Given this list of marker genes FNDC3B, TSPYL5, PLLP, RAB33A, BEX1, LACC1, SLC11A2, CFH, CD200, DNAJB2, HIVEP2, ITM2A, IFIT3, ZNF91, GLMP, LINC01943, PAQR3, DUSP5, ITPR1, ZSCAN30, ASAH1, BEX2, VCAM1, FOXN3, RNF213, H2BC5, CXCL16, MTRES1, MOBP, ZNF678, HEXA, NR1D2, STC2, LRRC1, TFEC, KCTD7, ATP2C1, MYLIP, ACSL5, HMOX1, CEBPD, SIPA1L2 (signal induced proliferation associated 1 like 2), APOLD1, PLPP3, OSMR, PARP6, HES4, ENTPD1, PIK3C2B, DNASE2, CPQ, KALRN, INPP1, ACP5, SNHG7, RSAD2, CEBPB, TNFAIP3, H2AJ, C11orf96, FRMD3, KHNYN, COL4A1 (collagen type IV alpha 1 chain), DIRAS3, RECK, PCTP, TFPI, RGS2, SMOX, ETFRF1, PARD3B, VPS41, RANBP3, SDC4, LRIF1, FAM167B, PTPRM, OPN3, IFIH1, JAG1, H2AC6, COLEC12, H1-0, CXCL3, SEL1L, LETMD1 (NCBI Gene Id 25875), ERAP1, KDM2A, CDH11, HNMT, TPP1, ST3GAL5, PTGFRN (NCBI Gene Id 5738), IL1R1, ITGA1, GABBR1, SPATA18, ANKRD6, IL7R, ATF3, USP47, SMARCE1, CD109, H2AC18, KLF4, ACVR2B, CEACAM1 (NCBI Gene Id 634), MYL9, FBN1, QPCT, CREG1, DKK3, GCNT2, CD58, PCMTD1, ART4, RAPGEF5, GALNT11, ZFP36L1, PLAAT4, BIVM, C2CD2, RORA, LRRC8B, LIMCH1, SSH1, HEY1, ZNF71, CYB5R1, NUDT16, TMEM45A (transmembrane protein 45A), CXCL6, SH3KBP1, MARCHF3, ITFG1, CEP290, ZNF267, CRACD, IFI44, GVINP1 (GTPase, very large interferon inducible pseudogene 1), ENTPD4, CRISPLD1, CNPPD1, CASP1, PDZD2, IFIT2, FLT1, VLDLR, ACTA2, NFIL3, IGF2R, ATL1, SAR1A, SPAG16, RIT1, ZNF503, TLR3, CHD2, ZNF667-AS1, ADAMTS18, PLEK2, ABHD5, TXNIP, GFPT1, MESD, RFTN1, EPSTI1 (epithelial stromal interaction 1), LYRM7, KCNJ2, SLC40A1, ZNF655, PPM1D, CFB, TCN2, ANKRD12 (ankyrin repeat domain 12), CAST, STX12, PCDH17, ICAM1, BRWD1, PAPPA, TCTA, LRRC32, CTNS, COL5A1, TSPAN31, TSC22D1, GLCCI1, SOD2, CHST2 (carbohydrate sulfotransferase 2), CHN2, SNX29, KLHL6, PITPNM3, GDF3, OLAH, GPRASP3 (NCBI Gene Id 80823), APH1B, SLC25A51, CPPED1, EDNRB, CCL2, SLC2A3, LPP, PTPN4, DUSP4, PRCP, KIF16B, SCAMP1-AS1, APOL1, LGALSL, FBXO22, TNFRSF11A, SMCR8, PRNP, ALDH6A1, NNT-AS1, RNF13, ARID5B, GLIDR, PPP1R3C, EMC6, MID2, ZSCAN29, SESN3, C6orf58 (NCBI Gene Id 389429, chromosome 6 open reading frame 58), ENDOD1, TCIM, TGFA, HOXB7, GLIS3, COA7, COX7A1, PER3, HMCN1, SERPINE2, NR3C1, GDAP1, SELE, CROT, LY75, ARRB1, NDRG4, ZNF702P, ZBTB8A, TMEM200A, BTN3A3, FAM200B (family with sequence similarity 200 member B), TMEM127, LGALS3BP, CSF1, KLHL21 (NCBI Gene Id 9903), TREX1, PELI1, RAB22A, PRKAB2, TFPI2, EMCN, ARHGAP26, CASP7, FNIP2, OLFML3, BST1, TRIB2, ITGA4, TMEM167B, TAGLN, MIR3142HG, ZEB2 (NCBI Gene Id 9839), AP1S2, TAPBP, PTGS1, CXCL5, NR1D1, DUSP23, ADAM23, BIRC3, PCDHA9, CDC42EP5, CXCL1, IFRD1, BAMBI, HTR2B, F8A1, HTATIP2, TANC2, ZNF721, TRIM16, SH3YL1, TMED4, SLC2A12, CLPB, CFI, TRIM52-AS1, NPIPA1, IL15, MAFB, OSTM1, ABCA1, LAMP3, PMP22, COL27A1, PCGF5, MAN1C1, ITPR2, CXCL2, ZNF302, here is a description of the gene set: species: Homo sapiens Human Gene Set: HORIUCHI_WTAP_TARGETS_UP Wilms' tumor 1-associating protein (WTAP) has been reported to be a ubiquitously expressed nuclear protein. Although a relation to splicing factors has been postulated, its actual physiological function still remains to be elucidated. To investigate the role of WTAP, we generated WTAP-knockout mice and performed small interfering RNA (siRNA)-mediated knockdown analyses in primary cultured cells. In DNA microarrays using human umbilical vein endothelial cells, WTAP-targeted siRNA treatment resulted in markedly reduced expression of cell-cycle-related genes. siRNA-mediated WTAP knockdown down-regulated the stability of cyclin A2 mRNA through a nine-nucleotide essential sequence in cyclin A2 mRNA 3' UTR. WTAP knockdown induced G2 accumulation, which is partially rescued by adenoviral overexpression of cyclin A2. Moreover, WTAP-null mice exhibited proliferative failure with death resulting at approximately embryonic day 6.5, an etiology almost identical to cyclin A2-null mice. Collectively, these findings establish WTAP as an essential factor for the stabilization of cyclin A2 mRNA, thereby regulating G2/M cell-cycle transition. from publication Horiuchi K, Umetani M, Minami T, Okayama H, Takada S, Yamamoto M, Aburatani H, Reid PC, Housman DE, Hamakubo T, Kodama T (PMID 17088532) Genes up-regulated in primary endothelial cells (HUVEC) after knockdown of WTAP by RNAi.